Given this list of marker genes ZNFX1, DOCK8, STAT2, PIK3R1, CD70, IKBKG, MCM10, TLR7 (NCBI Gene Id 51284), FCGR3A, DOCK2, CD3D, CD28, PTEN, CTPS1, FOXN1, PIK3CD, MAGT1 (magnesium transporter 1), CD27, ADORA2A (adenosine A2a receptor), XIAP, RAC2, ISG15, NFKBIA, TGFB1, IL2RA, IL2RB, DNASE2, LAT, SH2D1A, IRF7, TPP2, CARD11 (caspase recruitment domain family member 11), REL, RFXANK, DEF6, BLM, TRAC, SASH3, PGM3, TAP2, here is a description of the gene set: Severe viral infection species: Homo sapiens An unusually severe viral infection. Human Gene Set: HP_SEVERE_VIRAL_INFECTION